The following is a description of a gene set: Severe demyelination of the white matter A severe loss of myelin from nerve fibers in the central nervous system. studied in species Homo sapiens Human Gene Set: HP_SEVERE_DEMYELINATION_OF_THE_WHITE_MATTER, and this is the list of marker genes: PIGG, PPP1R15B, PYCR2, TRMT10A, PRPS1, MMACHC, L2HGDH